The following is a description of a gene set: Mouse Gene Set: GOBP_NEGATIVE_REGULATION_OF_SIGNAL_TRANSDUCTION_IN_ABSENCE_OF_LIGAND Any process that stops, prevents or reduces the frequency, rate or extent of signal transduction in absence of ligand. species: Mus musculus, and this is the list of marker genes: Bcl2l10, Col2a1, Il1b, Il7, Gdnf, Snai2, Eya4, Ctnna1, Prdx2, Eya2, Eya1, Cx3cl1, Klf4, Gfral, Hspa1b, Gas1, Map2k5, Tert, Nrg1, Fyn (NCBI Gene Id 14360), Csf2, Eya3, Ripk1, Mcl1, Unc5b, Fgf10, Tnf, Bcl2, Sgk3, Agap2, Mapk7 (NCBI Gene Id 23939), Stradb, Gata1